Given this list of marker genes FAM136A, ZNF423, RNF138, SNN, SLC25A4 (solute carrier family 25 member 4), MDK, KIFAP3, MARCKSL1, KCTD15, LPAR4, IFRD1, SATB1, LRFN4, NEO1, BASP1, BYSL, SLC22A3, HBE1, MAK16, B4GALT2, PKM, TULP4, SH3GL3, ADGRL1, PRPH2, SMARCD3, SPATS2, PAFAH1B3, ARMCX1, PFN2, PPIC, PTN, BNC1, POLR1E, TMEM47, LDB2, PLK2 (polo like kinase 2), RWDD1, SOCS6, NNAT, LXN, PNO1, MEX3D, PTBP2, MFAP2, KLHL22, TRPS1, ACKR3, GRWD1 (glutamate rich WD repeat containing 1), ARMCX2, PDZD2, CPM, HMGN1, SLC39A6 (NCBI Gene Id 25800), FGFR1, HBZ, CCN4, GOLT1B, RBM34, PFDN4, PXDN, COLEC12, TRO, RPRM, FKBP10, COL5A2, TSPYL4, SERPINH1, CTBP2, RAB11FIP3, LRP12, RCN1, NES, NPAS2, NR2F1, PCOLCE2 (NCBI Gene Id 26577), SERPINE2, LARGE1, FZD2 (NCBI Gene Id 2535), SEPTIN6, POGK, RECK, FLRT3 (fibronectin leucine rich transmembrane protein 3), TBX3, PRRX2, PDZRN3, CYSLTR1, GJA1, IGF2BP2, OBI1, GAS1, MGAT5, PITX2, CTPS1, GJC1, CBFB, PDGFC, NDN, MYCN, TTC3, SMARCA1, SEMA3D, HEPH, CDK14, RARB, FGF13, IGFBP5, RHOB, DLG3, GDF10, MEST, TGFB2, RRP8, TGIF1, CAPN6, EMCN, SRSF7, WLS, ITGA8, TMEM184C, EVL, SRM, SYNE2, UTP3, HMGA2, MAP4K1, ASB4, FKBP3, TSPAN6, EHBP1, CSRP2, HMGN3 (NCBI Gene Id 9324), ARPP19, ADGRL2, TBCB, PGK2, CD248, SLC12A2 (solute carrier family 12 member 2), EFNB2, MORF4L1, GPC1, SMARCA2, CDH16, TMEFF1, JUN, AKT3, PDGFRA, SMYD2, CST6, WT1, UCHL3, WASF1, PDPN, HAND2, CRABP2, RCN2, PTPRS, PLOD2, ID3, PLS3, HDAC2, EDNRB, AFAP1, TMEM50B, SEMA3A, FAM174B, here is a description of the gene set: studied in species Mus musculus Human Gene Set: CAIRO_LIVER_DEVELOPMENT_UP Genes up-regulated at early fetal liver stage (embryonic days E11.5 - E12.5) compared to the late fetal liver stage (embryonic days E14.5 - E16.5). from publication Cairo S, Armengol C, De Reyniès A, Wei Y, Thomas E, Renard CA, Goga A, Balakrishnan A, Semeraro M, Gresh L, Pontoglio M, Strick-Marchand H, Levillayer F, Nouet Y, Rickman D, Gauthier F, Branchereau S, Brugières L, Laithier V, Bouvier R, Boman F, Basso G, Michiels JF, Hofman P, Arbez-Gindre F, Jouan H, Rousselet-Chapeau MC, Berrebi D, Marcellin L, Plenat F, Zachar D, Joubert M, Selves J, Pasquier D, Bioulac-Sage P, Grotzer M, Childs M, Fabre M, Buendia MA (PMID 19061838) Hepatoblastoma, the most common pediatric liver cancer, is tightly linked to excessive Wnt/beta-catenin signaling. Here, we used microarray analysis to identify two tumor subclasses resembling distinct phases of liver development and a discriminating 16-gene signature. beta-catenin activated different transcriptional programs in the two tumor types, with distinctive expression of hepatic stem/progenitor markers in immature tumors. This highly proliferating subclass was typified by gains of chromosomes 8q and 2p and upregulated Myc signaling. Myc-induced hepatoblastoma-like tumors in mice strikingly resembled the human immature subtype, and Myc downregulation in hepatoblastoma cells impaired tumorigenesis in vivo. Remarkably, the 16-gene signature discriminated invasive and metastatic hepatoblastomas and predicted prognosis with high accuracy.